Given this list of marker genes GLDC, ATP1A4, PLPP3, ITGAM, MAGI1, ALDOC, ATP13A5, GJA1, SLC6A20, PLA2G7, GSN, SOX8, MLPH, CD63, CLU, MATN4 (NCBI Gene Id 8785), SPARCL1, ZNF780A, SPARC, HEPACAM, PRDX6, DIP2A, MT1F, CLDN5, C1QA, BCAN, EMX2, STAB1, CST3, GPR37L1, MFGE8, AQP4, SEPTIN4, ATP1A2, ID3, GLUL, ITGB5, NCAN, S1PR1 (sphingosine-1-phosphate receptor 1), APOE, LYZ, GFAP, DBI, here is a description of the gene set: species: Mus musculus Molecular approaches to understanding the functional circuitry of the nervous system promise new insights into the relationship between genes, brain and behaviour. The cellular diversity of the brain necessitates a cellular resolution approach towards understanding the functional genomics of the nervous system. We describe here an anatomically comprehensive digital atlas containing the expression patterns of approximately genes in the adult mouse brain. Data were generated using automated high-throughput procedures for in situ hybridization and data acquisition, and are publicly accessible online. Newly developed image-based informatics tools allow global genome-scale structural analysis and cross-correlation, as well as identification of regionally enriched genes. Unbiased fine-resolution analysis has identified highly specific cellular markers as well as extensive evidence of cellular heterogeneity not evident in classical neuroanatomical atlases. This highly standardized atlas provides an open, primary data resource for a wide variety of further studies concerning brain organization and function. Genes enriched in astrocytes in the adult mouse brain identified through correlation-based searches seeded with the astrocyte cell-type specific gene expression patterns. Human Gene Set: LEIN_ASTROCYTE_MARKERS from publication Lein ES, Hawrylycz MJ, Ao N, Ayres M, Bensinger A, Bernard A, Boe AF, Boguski MS, Brockway KS, Byrnes EJ, Chen L, Chen L, Chen TM, Chin MC, Chong J, Crook BE, Czaplinska A, Dang CN, Datta S, Dee NR, Desaki AL, Desta T, Diep E, Dolbeare TA, Donelan MJ, Dong HW, Dougherty JG, Duncan BJ, Ebbert AJ, Eichele G, Estin LK, Faber C, Facer BA, Fields R, Fischer SR, Fliss TP, Frensley C, Gates SN, Glattfelder KJ, Halverson KR, Hart MR, Hohmann JG, Howell MP, Jeung DP, Johnson RA, Karr PT, Kawal R, Kidney JM, Knapik RH, Kuan CL, Lake JH, Laramee AR, Larsen KD, Lau C, Lemon TA, Liang AJ, Liu Y, Luong LT, Michaels J, Morgan JJ, Morgan RJ, Mortrud MT, Mosqueda NF, Ng LL, Ng R, Orta GJ, Overly CC, Pak TH, Parry SE, Pathak SD, Pearson OC, Puchalski RB, Riley ZL, Rockett HR, Rowland SA, Royall JJ, Ruiz MJ, Sarno NR, Schaffnit K, Shapovalova NV, Sivisay T, Slaughterbeck CR, Smith SC, Smith KA, Smith BI, Sodt AJ, Stewart NN, Stumpf KR, Sunkin SM, Sutram M, Tam A, Teemer CD, Thaller C, Thompson CL, Varnam LR, Visel A, Whitlock RM, Wohnoutka PE, Wolkey CK, Wong VY, Wood M, Yaylaoglu MB, Young RC, Youngstrom BL, Yuan XF, Zhang B, Zwingman TA, Jones AR (PMID 17151600)